The following is a description of a gene set: Mouse Gene Set: GOMF_ORGANIC_ACID_TRANSMEMBRANE_TRANSPORTER_ACTIVITY studied in species Mus musculus Enables the transfer of organic acids from one side of a membrane to the other. Organic acids are acidic compound containing carbon in covalent linkage., and this is the list of marker genes: Slc16a3, Slco1b2, Slc38a3, Slco1c1, Sfxn3, Grin2c, Slc6a20a, Slc1a7, Slc16a10, Abcd1, Slc16a13, Slc26a10, Slc38a9, Slc25a29, Slc16a1, Slc36a4, Slc38a6, Slc16a12, Slc25a15, Slc25a11, Slc47a2, Slc15a4, Slc16a4, Slc25a44, Slc23a1, Slc7a4, Slc26a2, Slc6a11, Abcc3, Slc26a1, Slc19a1, Slc6a1, Slc1a5, Slc16a7, Slc10a7, Slc6a13, Slc22a7, Gria3, Slco1a7, Slc7a5, Slc26a8, Slc7a11, Ctns, Slc25a13, Slc6a5, Slc22a6, Gria4, Mpc1, Slc10a3, Slc25a32, Abcd3, Slc22a28, Slc3a2, Slc16a11, Slc25a12, Slc1a4, Fabp2, Mpc2, Ucp2, Slc5a8, Slc27a2, Slc25a18, Slc7a12, Grid1, Slc7a1, Slc32a1, Slc25a2, Slc36a1, Fabp4, Slc47a1, Slc17a7, Slc1a3, Slc6a20b, Slc25a26, Slc1a2, Slc25a22, Abcd4, Grik2, Slc13a3, Slc10a5, Slc25a21, Gria2, Fabp3, Ceacam2, Slc6a14, Slc7a2, Slc7a15, Slc7a13, Slc38a7, Slc1a6, Slc17a8, Slc22a19, Slc10a4-ps, Grik4, Slc38a5, Pdpn, Gria1, Slc43a1, Slc6a12, Slc38a4, Slc25a38, Slc29a4, Slc2a1, Abcd2, Slc26a6, Slc38a11, Slc27a6, Slc5a6, Slco1a4, Sfxn1, Slc17a6, Slc7a6, Grin2a, Slco2b1, Slc16a5, Mfsd12, Cd36, Slc16a6, Slc26a3, Slc19a3 (solute carrier family 19, member 3), Grid2, Slc26a5, Slc7a14, Slc7a8, Slc22a30 (solute carrier family 22, member 30), Slc27a1, Slc10a2, Slc10a4, Slc6a6, Slc6a7, Slc43a2, Slc38a8, Slc22a27, Slc13a2, Slc26a7, Slc16a9, Slc6a9, Slco1a5, Slc26a9, Slc35d2, Nherf1, Abcg2, Abcc4, Grin2b, Slc25a1, Slco1a1, Slc7a9, Slc22a13, Grik3, Abcb11, Tspo2, Slco1a6, Sfxn5, Nat3 (N-acetyltransferase 3), Slc51b, Slc16a14, Slc27a5, Slc16a8, Slc38a2, Slc22a2, Abcb1a, Ceacam1, Slc27a4, Slc5a12, Abcc1, Slc36a2, Slc43a3, Grin3b, Slc36a3, Slc10a6, Grik5, Slc66a1, Slc26a4, Abcb1b, Slc38a10, Slc13a5, Grin3a, Slc7a7, Abcc2 (NCBI Gene Id 12780), Mfsd2a, Slc51a, Slc7a3 (solute carrier family 7 (cationic amino acid transporter, y+ system), member 3), Grin1, Slc17a5, Slc35d1, Fabp1, Slc46a1, Slc6a8, Grik1, Fabp5, Grin2d, Slc22a29, Slc1a1, Slc38a1, Slc23a2, Slc6a15, Slc10a1, Slc25a10, Slc7a10, Slc22a26, Slco1a8 (NCBI Gene Id 632662)